The following is a description of a gene set: Human Gene Set: HP_ABNORMAL_SACROILIAC_JOINT_MORPHOLOGY An anomaly of the sacroiliac joint, which connects the base of the spine (sacrum) to the ilium (a hip bone). Abnormal sacroiliac joint morphology species: Homo sapiens, and this is the list of marker genes: TWIST2, TNFRSF1A, FGFR3, PHEX, ENPP1, HLA-B (major histocompatibility complex, class I, B), DMP1, RUNX2